Given this list of marker genes DACT3, TIRAP, ADAM9, NELL1, PKN1, PRKCSH, ITGB3, PKP2, YWHAG, DACT2, C1QBP, FEZ1, CCDC88A, ADD3, PDLIM5, RACK1, ABL1, TDG, HSPB1, DACT1, AVPR1A, ADCY6, TWF2, SDC4, ADCY4, MARCKS, UGT1A7, NELL2, LDB3, CAVIN2, UGT1A10, SQSTM1, PLEK, PRKD1, PICK1, HDAC5, GLRX3, CAVIN3, PRKD2, TOP2A, HDAC7, IRS1, GRK5, ITGAV, PRKCB, TRPV4, AVPR1B, DSP, HINT1 (NCBI Gene Id 3094), HDAC9 (NCBI Gene Id 9734), here is a description of the gene set: Human Gene Set: GOMF_PROTEIN_KINASE_C_BINDING species: Homo sapiens Binding to protein kinase C.